Given this list of marker genes DPP9, ADAR, KRT5, SASH1, PIGN, here is a description of the gene set: Hyperpigmented/hypopigmented macules studied in species Homo sapiens Human Gene Set: HP_HYPERPIGMENTED_HYPOPIGMENTED_MACULES